The following is a description of a gene set: A cell cycle checkpoint that detects and negatively regulates progression from G1 to S phase as part of a mitotic cell cycle. Human Gene Set: GOBP_MITOTIC_G1_S_TRANSITION_CHECKPOINT_SIGNALING species: Homo sapiens, and this is the list of marker genes: CDKN1A, RFWD3, TREX1, TP53, PRKDC, SDE2, GIGYF2, DGKZ, WAC, CCND1, MUC1 (mucin 1, cell surface associated), PLK3, RPA2, TRIAP1, CDK2, RPS27L, FBXO31